The following is a description of a gene set: studied in species Mus musculus A process in which a protein is transported to, or maintained in, a location within a ciliary membrane. Mouse Gene Set: GOBP_PROTEIN_LOCALIZATION_TO_CILIARY_MEMBRANE, and this is the list of marker genes: Tub, Arl13a, Gga1, Rab29, Arl3, Wdr19, Ift80, Rabep1, Arl13b, Efcab7, Bbip1, Lztfl1